The following is a description of a gene set: Neighborhood of RAB7L1 RAB7, member RAS oncogene family-like 1 in the GNF2 expression compendium Neighborhood of RAB7L1 Human Gene Set: GNF2_RAB7L1 species: Homo sapiens, and this is the list of marker genes: GSAP, BIN2, KLRC3, ARL4C, BTN3A3, SUN2, PRKCH, GZMH, RAB29, PRF1 (perforin 1), KLRD1 (killer cell lectin like receptor D1), ABHD17A, CCL4, APOBEC3G, IL2RB, KLRF1, CTSW (NCBI Gene Id 8849), GPR65, CYTH1, STK10, GZMA, RUNX3, NKG7, PTPN4, NCR3, PTGER2, JAK1, PLAAT4, CD247, CYTIP, GNPTAB, RASSF1 (Ras association domain family member 1), TES